Given this list of marker genes Ccdc68, Cnih2, Ube3a, Ikzf1, Plcxd2, Bin1, Tmem254 (transmembrane protein 254), Slc25a23, Usp50, Fancc, Dcun1d3, Eng, Cacna1e, Abca5, Lrrc28, Prl3b1, Tbc1d7, Ssx2ip, Mov10l1, Pcdh19, Cartpt, Doc2g, Sel1l, Larp4, Zdhhc15, Tbc1d23, Nt5dc1, Hoxa9, Cbx6, Gng11, Fam120a, Magix, P4ha3, Brms1l, Actb, St8sia3, Pnpla6, Kif14, Fndc3a, Mdm2, Zfp950, Ncan, Sncb, Klf12, Lyz3 (NCBI Gene Id 77397), Mrpl50, Ccdc87, Snapin, Uqcrc1, Col1a1, Irx5, Tmem150b, Dedd, Otx1, Zfp867, Lrrc58, Sdc1, Pknox2, Rps6kc1, Ntng1, Tbc1d4, Necap2, Gzmb, Iws1, Tbc1d10b, Ifnar2, Fam117b, Slc18a1, Nectin1, Smap1, Zfp703, Rbfox2, Capzb, Isl1, Lhx6, Prkcb, Zfp763, Dmac2, Suz12, Mog, Kcnc3, Zfp637, Desi2, Tm9sf3, Pik3r3, Eeig1, Atg7, Frmd7, Chrm1, Hoxd11, Dlx3, Nfix, Gimap5, Igf2, Nrk, Tnfaip8l2, Eif2ak3, Srgap3, Zfp606, Sp1, Mab21l2, here is a description of the gene set: species: Mus musculus from publication Chen Y, Wang X (PMID 31504780) Genes predicted to be targets of miRBase v22 microRNA mmu_miR_12185_5p in miRDB v6.0 with MirTarget v4 prediction scores > 80 (high confidence targets). Mouse Gene Set: MIR_12185_5P